Given this list of marker genes PLEC, ITGB4, KRT14, KRT5, TGM5, CDSN, here is a description of the gene set: Human Gene Set: HP_INTRA_EPIDERMAL_BLISTERING Intra-epidermal blistering species: Homo sapiens A type of blistering in which the lesions are located within the epidermis with loss of cell-cell adhesion of keratinocytes. In simplex EB, cleavage occurs in the basal layer, which is the innermost layer of the epidermis and consists of a single layer of basal germinative cells (mostly epidermal Keratinocytes) that proliferate and thereby produce new cells for other epidermal layers. As the cells move towards the upper layers of the epidermis they mature and eventually form cornified cells. The suprabasal cell layer lies directly above the basal layer and is composed of five to ten layers of cells.